The following is a description of a gene set: Human Gene Set: GNF2_BNIP2 Neighborhood of BNIP2 BCL2/adenovirus E1B 19kDa interacting protein 2 in the GNF2 expression compendium Neighborhood of BNIP2 studied in species Homo sapiens, and this is the list of marker genes: GDI2, USP3, ELF4, PDCD6IP, GMFG, SSR1, BNIP2, MTDH, ARPC3, ACTR2, STAT6, HCLS1, MBD2, CDV3, EIF3L, FAM120A, SEC11A, RBM3, NACA, PHF21A, LAPTM5, TRAPPC8, PAK2, INTS8, ACTR3, WTAP, CLIC1, PAPOLA, DDX5, ATG12 (autophagy related 12), KDM5A, DOCK2, ADPGK, TYK2